The following is a description of a gene set: The chemical reactions and pathways involving androgens, C19 steroid hormones that can stimulate the development of male sexual characteristics. Mouse Gene Set: GOBP_ANDROGEN_METABOLIC_PROCESS species: Mus musculus, and this is the list of marker genes: Hsd3b6, Hsd17b11, Scarb1, Ugt2b35, Plekha1, Srd5a2 (steroid 5 alpha-reductase 2), Hsd17b7, Adm, Srd5a1, Cyp17a1, Inhba, Hsd3b2, Akr1d1, Spp1, Dhrs9, Esr1, Wnt4, Hsd17b4, Cyp19a1, Med1, Hsd17b10, Ugt2b36, Hsd17b3, Chst10, Tiparp, Hsd3b3, Sgpl1, Akr1c14, Hsd17b2, Hsd3b1, Hsd17b8, Shh